The following is a description of a gene set: Any process that results in a change in state or activity of a cell (in terms of movement, secretion, enzyme production, gene expression, etc.) as a result of a chemical stimulus indicating the organism is under stress. Human Gene Set: GOBP_CELLULAR_RESPONSE_TO_CHEMICAL_STRESS studied in species Homo sapiens, and this is the list of marker genes: RWDD1, HSF1, KDM6B, PYCARD, GPR37L1, MAPK8, ENDOG (NCBI Gene Id 2021), PENK, PLEC, FXYD2, RCSD1, SLC8A1, PDGFD, PEX5, OGG1, SLC25A14, ATF2, IL6, PJVK, CYP1B1, PRKAA2, PRDX3, TSPO, GPX8, SNCA, ABCC9, TMEM161A, ARNT, EIF2S1, AIF1, SIN3A, IL18BP, MAPK7, NFE2L1, GPX7, ZNF277, SELENOS, PXN, CASP3, AIFM2, FUT8, PARP1, MT3, PLEKHA1, MIR17, PTGS2, PAWR, ARHGEF2, SIRT2, NFAT5, SLC2A1, PRKN, MIR92A1, PYCR2, NPPA, XRCC6, KLF2 (NCBI Gene Id 51713), ATF4, TPM1, ATG7, AKR1B1, STK24, FANCD2, BNIP3, ATP1A1, ABL1, PEX10, VRK2, PEX13, MET, NME8, RIPK3, SRXN1, TRPV4, RPTOR, ERMP1, CCS, MAPKAP1, WNT16, SETX, ANKZF1, NINJ1, TMIGD1, TP53INP1, MYB, FBLN5, TRPV3, DDIT3, SLC25A23, PRDX1, TP53, SLC2A4, PML, MMP2, SLC25A24, NFE2L2, LRRC8D, ABL2, TRPM2, ZFP36L1, CDKN2A, AMBP, ABCC1, PNPT1, FOXO1, UCP1, PPARGC1A, CFL1, CUL3, USP15, CRYGD, MAPT, ATP2A2, IL18RAP, PIK3CA, WNK3, SOD2, MPV17, EPO (erythropoietin), STAU1, KLF4, GPX5 (glutathione peroxidase 5), PPIF, NLK, TRIM21, FAS, OXSR1 (oxidative stress responsive kinase 1), GCH1, SIRT1, MGST1, CASP1, WNK1, PDK2, PEX14 (NCBI Gene Id 5195), MIR34A, PYROXD1, CD36, PPEF2, NLRP3, PRKRA, FADS2, TREX1, RACK1, STK25, GPR37, HTRA2, NOS3, SRC, SELENON, PYCR1, TRPC6, EDNRA, LONP1, SLC7A11, CYGB, ECT2, CAT, PRKCD, ZFAND1, AKT1, CAMKK2, ERRFI1, PKD2, TET1, BTK, ABCB1, SCN7A, CLN3, HM13, BDKRB2, PPP5C, HSPA1B, RHOB, STOX1, STK26 (serine/threonine kinase 26), HSPA1A, FER, MAP3K5, MIR135A1, SOD1 (NCBI Gene Id 6647), KAT2B, SPHK1, MMP3, ROMO1, SCN2A, FBXO31, HGF, MIR103A1, STK39, CAPN3, ABCD1 (ATP binding cassette subfamily D member 1), DHFRP1, PRKD1, DNAJA1, OSER1, MIR133A1, PEX12, MIR21, NUDT2, ATP7A, EDN1, CBX8, SOD3, DAPK1, MPO, CDK1, STAU2, EFHD1, LRRC8C, PEX2, DHRS2, GDF15, RELA, PARK7, AQP1, ALDH3B1, XBP1 (X-box binding protein 1), FANCC, TXN, RELB, MSRA (methionine sulfoxide reductase A), LRRC8E, ADPRS, PDCD10, SLC11A2, CHCHD2 (NCBI Gene Id 92547), RBX1, ETV5, BRF2, SUMO4 (NCBI Gene Id 387082), TRPA1, MEAK7, VKORC1L1, ATM, MGAT3, MAPK13, AIFM1, MAP2K4, MAPK9, SLC12A6 (NCBI Gene Id 9990), MLST8, PCGF2, TRAP1, LCN2, ZNF580 (NCBI Gene Id 51157), SMPD3, BMAL1, MTOR, NOX1, YBX3, MIR132, APOA4, NR4A2, AQP5, PRDX2, VPS13A, CLCN2, MAP1LC3A, FABP1, MDM2, FBP1 (NCBI Gene Id 2203), BMP7, GSR, GATA5 (NCBI Gene Id 140628), SLC4A11, FXN, SLC1A1, MYLK, ARL6IP5, AGAP3, NCOA7, TBC1D24, RBM11, PINK1, FYN, G6PD, RIPK1, PNPLA8, RAD52, BAD, NET1, SIRPA, ALOX5, PTPRK, FOXO3, PRR5L, HIF1A, STX4, OXR1, HDAC6, ATG5, PPIA, PRKAA1, EIF2AK3, SERPINB6, EZH2, HDAC2, ERCC6L2, BECN1, TIFAB, LETM1, LRRK2, DDX3X, ZC3H12A, MIR107, DDR2, SESN2 (NCBI Gene Id 83667), PCNA, PDGFRA, MB, KEAP1, MIRLET7B, NAGLU, FOXP1, ATP13A2, TNFAIP3, DHFR, MICU1, CAB39, STX2, PRDX5, TOP2B, CAV1, NQO1, ERN1, PRKCI, GPX1, FOS, PLA2R1, RPS3